Given this list of marker genes HOXA5, LIF, YAP1, NKX2-1, TNC, FGF10, EXT1, SPRY2, MAP2K2, TNF, MAPK1, MAPK3, RPL13A, LAMA1, WNT7B, SPRY1, COL6A1, CELSR1, PITX2, FOXA1, RSPO2, FGF8, CTNNB1, MAP2K1, ESRP2, FOXF1, SHH, GRHL2 (NCBI Gene Id 79977), CDC42, CTSZ, PLOD3, KRAS, TBX2, TGFBR2, NOG, SEC24B, VANGL2, SRF, FOXP2, WNT2, TCF21, NFIB, FGFR2, DAG1, CTSH, AP3B1, SOX9, HMGA2, SRSF6, STK40, RDH10, ID1, DLG5, WNT2B, SOX11, BMP4, FGF7, HHIP, IGF1, HIPK2, NODAL, here is a description of the gene set: Human Gene Set: GOBP_LUNG_MORPHOGENESIS species: Homo sapiens The process in which the anatomical structures of the lung are generated and organized.